Given this list of marker genes SLC2A1, LALBA, B4GALT1, here is a description of the gene set: Synthesis of the disaccharide lactose takes place within the Golgi apparatus of epithelial cells of the lactating mammary gland. The synthesis itself is a single chemical reaction of free glucose and UDP-galactose to form lactose and UDP. For this reaction to occur, glucose is transported from the cytosol into the Golgi lumen, and B4GALT1 interacts with LALBA (alpha-lactalbumin) to modulate its substrate specificity. Reactome Pathway: Lactose synthesis part of: Metabolism of carbohydrates and carbohydrate derivatives studied in species Homo sapiens